Given this list of marker genes Gclm, Atm, Adh5, Dusp6, Dnaja1, Stox1, Park7, Atg5, Ddit3, Gclc, here is a description of the gene set: species: Mus musculus Any process that results in a change in state or activity of a cell or an organism (in terms of movement, secretion, enzyme production, gene expression, etc.) as a result of a nitrosative stress stimulus. Nitrosative stress is a state often resulting from exposure to high levels of nitric oxide (NO) or the highly reactive oxidant peroxynitrite, which is produced following interaction of NO with superoxide anions. Mouse Gene Set: GOBP_RESPONSE_TO_NITROSATIVE_STRESS